The following is a description of a gene set: studied in species Mus musculus The chemical reactions and pathways resulting in the formation of a polyol, any alcohol containing three or more hydroxyl groups attached to saturated carbon atoms. Mouse Gene Set: GOBP_POLYOL_BIOSYNTHETIC_PROCESS, and this is the list of marker genes: Sptssa, Spr, Ipmk, Agk, Impa2, Pcbd2, Pou1f1, Gper1, Scp2, Itpkb, Cyp24a1, Ippk, Acer3, Impa1, Sptlc1, Plcg1, Sptlc2, Pth, Cyp27a1, Mas1, Plek, Adcyap1r1, Cyp2r1, Prkg1, Ip6k3, Asah1, Pth1r, Plcg2 (phospholipase C, gamma 2), Pts, Cyp27b1, Lep, Gba1, Gch1, Itpkc, Pcbd1, Pck1, Pgp, Ip6k2, Ip6k1, Myh9, Sptssb, P2ry1, Itpka, Sptlc3, Ephx1, Isyna1, Ppip5k1, Snca, Ppip5k2, Pck2, Plcd1, Dhfr, Akr1b1, Cd244a, Asah2, Abca2, Acer1, Sphk1, Sphk2, Lhcgr, Acer2, Ptafr, Qdpr, Got1, Avpr1b, P2ry6, Ntsr1